The following is a description of a gene set: Human Gene Set: YAO_TEMPORAL_RESPONSE_TO_PROGESTERONE_CLUSTER_12 Human infertility and recurrent pregnancy loss caused by implantation defects are poorly understood. Hoxa-10-deficient female mice have severe infertility and recurrent pregnancy loss due to defective uterine implantation. Gene expression profiling experiments reveal that Hoxa-10 is an important regulator of two critical events in implantation: stromal cell proliferation and local immunosuppression. At the time of implantation, Hoxa-10 mediates the progesterone-stimulated proliferation of uterine stromal cells. Hoxa-10 mutants express a stromal cell proliferation defect that is accompanied by quantitative or spatial alterations in the expression of two cyclin-dependent kinase inhibitor genes, p57 and p15. Hoxa-10 deficiency also leads to a severe local immunological disturbance, characterized by a polyclonal proliferation of T cells, that occurs in place of the normal progesterone-mediated immunosuppression in the periimplantation uterus. Genes co-regulated in uterus during a time course response to progesterone: SOM cluster 12. studied in species Mus musculus from publication Yao MW, Lim H, Schust DJ, Choe SE, Farago A, Ding Y, Michaud S, Church GM, Maas RL (PMID 12554760), and this is the list of marker genes: PTGR1, ENSA, IFNAR2, EMP3, ERGIC3, SLC39A8, HSD17B10 (hydroxysteroid 17-beta dehydrogenase 10, NCBI Gene Id 50828), PDCD6, NTAN1, C1QB, NSDHL, GNG11 (NCBI Gene Id 2791), H2AC8, RBMX, CKS2, NTPCR, CASP8, PCP4, IARS2, GNAI2, CD44 (CD44 molecule (IN blood group)), TMEM176A, PLEKHO1, RPL13A, FXYD2, PIK3C3, ARPC1A, ATP6AP2, S100A1, GSTK1, PTGIS, MDK, H2BC4, HIGD2A, LGALS3BP, HIKESHI, PC, SNAPC2, QARS1, FDFT1, HMGN2, SHD (Src homology 2 domain containing transforming protein D), TRIM59, ANTXR2, EBF1 (EBF transcription factor 1), GNA12, ZFTRAF1, AKR1B10, MPDU1, FKBP9, OXCT1, WDR83OS, NAP1L1, IDH1, RPA3, RBP1, AHCY, DECR1, PSME1, FKBP7, GGH, IDH2, S100A11, MCM3, NUDT21, ELOVL6, MAGED2, RBMS2, RAB3D, FARS2, PHPT1, CAPNS1, RRAS, CLN6, ARL6IP5, CHPT1, ALDH2 (NCBI Gene Id 217), ACP1 (NCBI Gene Id 52), EXOC4, CIRBP